The following is a description of a gene set: studied in species Mus musculus Mouse Gene Set: GOBP_CARDIAC_CHAMBER_MORPHOGENESIS The process in which a cardiac chamber is generated and organized. A cardiac chamber is an enclosed cavity within the heart., and this is the list of marker genes: Fgfr2, Sav1, Acvr1, Zfpm2, Mef2c, Fgf9, Pou4f1, Adamts19, Tgfbr3, Heg1, Myh6, Mybpc3, Jag1, Mir20a, Ptcd2, Mks1, Hand2os1, Med1, Lrp6 (low density lipoprotein receptor-related protein 6), Vangl2, Gata4, Tbx3, Bmp5, Tbx5, Pkp2, Id2, Ovol2, Rbp4, Tgfbr2, Foxf1, Heyl, Sox11, Cpe, Naglu, Tgfb1, Aplnr, Smarcd3 (SWI/SNF related, matrix associated, actin dependent regulator of chromatin, subfamily d, member 3), Ift88, Ryr2, Smad4, Hes1, Mdm2, Ly6e, Msx2, Eng, Ctnnb1, Smo, Hey2, Slit2, Bmp7, Npy2r, Nfatc1, Fkbp1a, Ccm2l, Sos1, Shox2, Adprhl1, Bmpr2, Grhl2, Smarca4, Prox1, Ppp1r13l, Klk1b1, Fhl2, Foxh1, Gja5, Hey1, Ube4b, Tbx20, Slit3, Myl3, Sema3c, Pitx2, Wnt11, Tbx1, Parva, Dsp, Bmp10, Robo2, Pcdha9 (protocadherin alpha 9), Nog, Tgfb2, Nrp1, Epor, Nkx2-5, Mesp1, Bmp2, Smad7, Rxra, Fgf8 (NCBI Gene Id 14179), Dll4, Foxc1, Bmpr1a, Cav3, Myh7, Mir18, Zfpm1, Foxc2, Ednra, Fzd1 (NCBI Gene Id 14362), Ahr, Hand1, Fgfrl1, Cited2, Isl1, Dnah11, Myl2, Gsk3a, Notch2, Chd7, Egln1, Col11a1, Robo1, Hand2, Fzd2, Eva1a, Tpm1, Trp53, Rbpj, Mir17, Notch1, Sox4, Srf, Nos3, Tnni1, Gata3, Gata6, Tek, Npy5r, Dhrs3, Rbm15, Sfrp2, Bmp4, Epo, Tnni3, Tbx2, Nsd2, Mir92-1, Nrg1, Adamts1, Ccn1, Rnls, Dvl3, Smad6, Tnnc1, Tgfbr1, Cfc1, Wnt2, Mir19a, Adgrg6, Mir19b-1, Hif1a, Nrp2, Tnnt2, Lrp2